Given this list of marker genes AP4E1, ASCC3, IRF6, SLC25A24, HNRNPK, H3-3A, SNIP1, GLIS3, SNORD115-1, MKRN3, GALNT2, STRADA, SLC2A1, KCNJ5, KCNK9, RAD21, SARS1, ADARB1 (adenosine deaminase RNA specific B1), RAB11B, NCAPD3, PREPL, PGAP3, ZMIZ1, AGL, GJA8, TNRC6B, TRRAP, ZFX (NCBI Gene Id 7543), CEP295, WARS2, WAC, PPM1D, MID1, PIGO, IER3IP1, CLP1, CHMP1A, CDK6, VPS35L, PGAP2, APC, PRKACB, TMEM53, PPP2R1A, EDARADD, NOG, ANKRD11, ALG12, TMEM237, ZNF462, HS2ST1, CDH2, FZD2, BCR, GLI2, MEF2C, TASP1, RPS7, OPHN1, ACTB, IRX5, ASPM, TUBGCP2, EP300, HK1, WDR62, SLC25A46, DVL1, WDR19, OGT, FAR1, QRICH1, HNRNPU, STEEP1 (STING1 ER exit protein 1), EIF5A, MAN1B1, PACS1, MED12L, SCN4A, TRAPPC9, PDE4D, RNU4ATAC, SMAD4, KDM3B (lysine demethylase 3B), ODC1 (ornithine decarboxylase 1), NODAL, SOX4, PUF60, ABCC9 (NCBI Gene Id 102724274), CDK10, THOC6, KMT2D, METTL5 (methyltransferase 5, N6-adenosine), SHH, FGFR1, SPEN, DENND5A, FOXG1, TMEM94, CRIPTO, SETBP1, HUWE1, FBXO28, CSNK2A1 (casein kinase 2 alpha 1), ZNF526, SMARCB1, SMARCD1, CDC42BPB, TOE1, PWRN1, PIGB, TWIST2, BUB1, DNMT3A, KNL1, EHMT1, CTCF, HDAC8, CEP152, KIF11, RNU4-2, EEF1A2, PITX2, MAP1B, BAP1, SLC4A10, EXT1, IGF1R, DIS3L2, ACTG1, TCF20, KAT6A, MEIS2, SLC1A3, AHDC1, CLCN3, UBE3B, CACNA1A, GPC4, RAP1B, AFF4, MFSD2A, AP3B1, DLL1, PIGT, SETD1A, SIX3, GNE, TBCK, CUX1, TLK2, KATNB1, AGR2, SEC23A, PWAR1, WARS1, TAF1, TTC5, SNRPN, MAPRE2, KDM1A, SATB2, NXN, CDK5RAP2, SMARCC2, MCM7 (minichromosome maintenance complex component 7), IL1RAPL1, CAPRIN1, CPLX1, CDK13, DDX59, CIT, GAS1, PACS2, PRKDC, OCRL, CRKL, CACNA2D1, MESD, MYT1L, ARHGEF2, PDGFRB, TRIO, YY1, RFX7, PIGN, PPP1R21, OTUD6B, NCAPG2, AFG2B, RHOBTB2, OTUD7A, SCN1A, NDN, ASXL2, MYMX, NSUN2, CHD2, CILK1, IQSEC2, MCTP2, AP4M1, GOLGA2, PPP1R15B, HOXB1, CHST14, ZNF407 (NCBI Gene Id 79610), IFT43, AGO2, BRCA1, TAF6 (NCBI Gene Id 6878), TGIF1, GNB2 (NCBI Gene Id 96628), PIGL, ZSWIM6, NRCAM, ZC4H2 (NCBI Gene Id 7493), KCNK4, SPECC1L, KDM4B, COL11A1, SIN3A, CEP63, ADSL (adenylosuccinate lyase), STIL, RSPRY1, KAT6B, MCPH1, NEXMIF, GJA5, ATN1, PIGK, GNAI1, AMMECR1, SYNGAP1, VPS51, CTNNB1 (NCBI Gene Id 1499), DPF2, ATIC, PLPBP, KDM5C, ALDH6A1 (NCBI Gene Id 4329), SMC1A, SETD5, ACBD6, HIVEP2, BMP2, LMBRD1, DISP1, BPTF, CREBBP, FGF8, UBAP2L, EDAR, KIF7, THUMPD1, DCHS1, DLK1, ADAMTSL2, COPB2, NFIA, PIEZO2, MTOR, FAT4, HNRNPC, PSMD12, SC5D, ASXL3, DPM2, TBCE, FLII, PCGF2, MKS1, GAD1, NAA20, EXOSC2, B3GLCT, SHMT2, EDA, PPP1CB, MICU1, UFC1 (ubiquitin-fold modifier conjugating enzyme 1), PPP2R5D, ANKRD17, PGM2L1, EPG5, RAI1, PYCR2, AP4S1, RALA, AP2M1, ESAM, TBC1D24, PIGV, CSF1R, SUPT16H, EBF3 (EBF transcription factor 3), STT3A, NSRP1, CHD8, ADNP, KMT2A, TRIP12, DHPS, DPM1, CYFIP2, CLCN6, SOX11, MPC1, DSE, STAG2, PTRH2, SMARCA2, POGZ, MAGEL2, SMPD4, DCPS, MED12, RYR1, TRMT10A, DDB1, MINPP1, ATP9A, MAF, SPTBN1, CASP2, MED13, MYO18B, SNORD116-1, NAA10, CCNQ, SYT1, ANKLE2, WDR4, EDEM3, H4C9, SRCAP, SIM1, BCKDK, ARX, PIGQ, RNF135, CDC42 (cell division cycle 42), IFIH1, BCL11A, PTCH1, TAF4, TCF3 (NCBI Gene Id 6929), PLAA, ADAMTSL1, PMM2, SLC9A7, TRAPPC10, TBL1XR1, AGO1, CDON, PIGY, SSR4, NAA80, WBP4, UNC80, CNOT2, GATAD2B, TPR (translocated promoter region, nuclear basket protein), MED27, CCNK, SLC6A1, CENPE, SH3PXD2B, H4C5, FIG4, CAMSAP1, USP9X, CEP135, RPL10, TMEM147, CHAMP1, ALG9, SMC3, ZBTB18, DHX9, RAPSN, SLC26A2, WNT5A, TAF13, PQBP1, TRAPPC14, PIGW, DYRK1A, ZNHIT3, WASHC4, ATP1A3, DEAF1 (DEAF1 transcription factor), CDH11, KCNJ6, GBA1, ARID1A, SRRM2, CLTC, MAPK8IP3, MYL2, COG1, NPAP1, DMPK, NIPBL, KDM6A, MAPK1 (NCBI Gene Id 5594), FOXH1, ATP6V1B2, PIGG, ZNF292, FBXO11, MYOD1, ARID2, BRAT1, OCA2, EDA2R, ADGRG6, ARMC9, ARID1B, SASS6, SMARCA4, ATP1A2, TGFB3, NALCN, AP4B1, PRKAR1B, KIF15, FBN1, SMARCE1, AARS1, PAK3, ATRX, HERC2, TRPS1, B4GALT1, NONO, INTS11, PBX1, SLC35A2, CDK19, LAS1L, TAF8, EXOC2, KCNJ2, MEG3, MECP2, MBD5, NUP37, KCNMA1, PIGU, FGFR2, WDR26, BCL11B, ROR2, SUFU, RTL1, AFF3, KCNH1, MSL3 (NCBI Gene Id 25867), ZIC2, PHC1, CACNA1C, PURA, JARID2, CNTNAP2, MED25, POLR3A, KIF14, PAX3, here is a description of the gene set: Human Gene Set: HP_ABNORMALITY_OF_UPPER_LIP_VERMILLION studied in species Homo sapiens Abnormality of upper lip vermillion An abnormality of the vermilion border, the sharp demarcation between the lip (red colored) and the adjacent normal skin.